The following is a description of a gene set: Any process that stops, prevents, or reduces the frequency, rate or extent of a response to nutrient levels. species: Mus musculus Mouse Gene Set: GOBP_NEGATIVE_REGULATION_OF_RESPONSE_TO_NUTRIENT_LEVELS, and this is the list of marker genes: Bbs4, Cartpt, Gfral, Nucb2, Ucn, Mkks, Gdf15 (NCBI Gene Id 23886), Spx, Npff, Lep, Ppara, Pyy, Bbs2, Nenf, Ghsr, Cck, Gcg